The following is a description of a gene set: part of: Virus Assembly and Release studied in species Homo sapiens For a budding influenza virus to be fully infectious is it essential that it contains a full complement of the eight vRNA segments. Two different models have been proposed for packaging of the vRNPs into newly assembling virus particles; the random incorporation model and the selective incorporation model.<br>The random incorporation model as its name suggests proposes that there is no selection at all on which vRNPs are packaged. It is assumed that each vRNP has equal probability of being packaged, and that if enough vRNPS are packaged a particular percentage of budding virions will receive at least one copy of each genome segment. This model is supported by evidence that infectious virions may possess more than eight vRNPs assuring the presence of a full complement of eight vRNPs in a significant percentage of virus particles. Mathematical analysis of packaging suggested that twelve RNA segments would need to be packaged in order to obtain approximately 10% of virus particles that are fully infectious, a number that is compatible with experimental data. Due to the low amount of RNA per virion (estimated at 1-2% w/w), enumeration of the precise number of RNAs packaged in a virion is difficult.<br>The selective incorporation model, suggests that each vRNA segment contains a unique "packaging signal" allowing it to act independently, with each vRNA segment being packaged selectively. There is increasing evidence to support the theory of a packaging signal within the coding regions at both the 5' and 3' end of the genomic RNA, with signals being reported for all segments except segment 7. The exact method by which individual vRNP segments are packaged is not known but it has been hypothesized to occur via specific RNA-RNA or protein-RNA interactions. This model is also supported by thin section electron microscopy images of influenza particles that show eight distinct "dots", presumably vRNPs within virus particles. Reactome Pathway: Packaging of Eight RNA Segments, and this is the list of marker genes: NS, HA, PB1, NP, PB2, PA, NA, M